The following is a description of a gene set: Human Gene Set: GSE2585_CD80_HIGH_VS_LOW_MTEC_DN from publication Derbinski J, Gäbler J, Brors B, Tierling S, Jonnakuty S, Hergenhahn M, Peltonen L, Walter J, Kyewski B (PMID 15983066) studied in species Homo sapiens Genes down-regulated in medullary thymic epithelial cells (mTEC): CD80 high versus low. Gene expression in different thymic stromal cells and subsets thereof was analyzed in 6-12 week old wild type (C57BL/6) and Aire knock-out (mixed background) mice. Thymic stromal cells were purified by sequential enzymatic digestion (collagenase, collagenase/dispase and trypsin) followed by gradient centrifugation and FACS sorting. Sort criteria were as follows: dendritic cells (CD11c+, F4/80 -), macrophages (F4/80+, CD11c-), cTECs (CD45–/lo, CDR1/Ly51+, Ep-CAM+) and mTECs (CD45–/lo, CDR1/Ly51–, Ep-CAM+). mTECs of wild-type and Aire knock-out mice were further subdivided according to CD80 expression levels. For microarray analysis total RNA from thymic stromal cell samples of two independent experiments was pre-amplified and biotinylated by two rounds of cDNA synthesis and in vitro transcription. Fluorescence readings were evaluated by using Microarray Suite 5.0 software., and this is the list of marker genes: UEVLD, HOOK1, MTMR14, POU3F2, PLCG2, LENEP, PDLIM1, SCN11A, GTPBP10, CDHR2, GNAT3, PIMREG, LILRA1, GARNL3, TRPC3, ZNF154, SPAM1, AURKAIP1, MORC1, STAP2, PPBP, MMP27, NR2C2, ADAM11, HMGB3P1, SCN2A, IL7, DARS1, TTLL1, DCTPP1, PDYN, OR10H1, PARK7, AGRP, HEXA-AS1, GPR176, DSE, AQP1, HSD17B3 (hydroxysteroid 17-beta dehydrogenase 3), PCDHGB5, APOBR, RAI14, IMPDH1, CDCA3, CCR4, EFNA5, KCNA10, HTN3, ATP8B4 (ATPase phospholipid transporting 8B4 (putative)), RFPL3, GUK1, GRIK1, WRNIP1, GPX5, LHX6, SSUH2, VTCN1, GPR20, PDGFA, ACSF2, TPCN1, ICA1, ZNHIT2, CAD, HIP1, TMSB10, ARSB, TMEM8B, ELOB, SLC35F6, OR7E47P, ZKSCAN5, STAT4, NEK3, NHP2, RXRG, CD1D, GDF10, MYL6, MCM2, PTTG3P, DHRS7B, RRAS, CRADD, ATP5MF, BAIAP2, CASQ2 (calsequestrin 2), SMPD3, RBP4, KRT32, AKR1B1, BCL2L11, LRRC32, CDSN, GRAMD1C, GRIA4, ZNF668, TNFRSF8, KLF5, BMERB1, ACP6, RPL12, MMP20, SLCO5A1, ASAP2, WDR18, CD59, SLC25A11, AFDN (afadin, adherens junction formation factor), KHDRBS2, POLR2L, ZC3H14, FCGR1A, RNASEH2A, SLC37A4, CLTA, CUX1, GPR75, CPM, SSR4, CRELD1, DGKG, DEF8, CAV1, TESK1, NPY, NR0B1, CTAGE1, ENOX1, RING1, DIRAS3, PLA2G2E, GPC4, LINC00474, RERGL, PRPH2, DNPH1, PFN2, SOD1, PTPN9, GS1-600G8.3, FANCE, ST3GAL6, COTL1, ECI2, DUOX1, IFT46, RBMY2FP, ARRB1, TUBA1C, USH2A, KDM4A, TST, TMEM158, CNOT1, SCRT1, HAPLN2, SKAP1, PIGT (NCBI Gene Id 94004), RMND5B, DNM3, GSTA4, B4GALT7, FARP2, MATN4, EPB41L3, ME3, PAAF1, COL18A1, SHB, PSMA1, PPIH, BCAP29, LY6G6E, FZD10, ANKMY1, TP53I3, B3GALT5, LIPG, FOXD3, OSGIN2, HBQ1, PRKACG, PMS2P2, TMEM47, RPL41, RPL10P17, C4BPB, CTPS2, ZNF480, PPIE, ANXA2P3, LHX2, AKR1A1, UROS, DCX